Given this list of marker genes ABCA11P (ATP binding cassette subfamily A member 11, pseudogene), NR1I3, C3orf86P (NCBI Gene Id 102724231), EREG, FAM110B, TUBE1, here is a description of the gene set: Human Gene Set: HOEK_MONOCYTE_2011_2012_TIV_ADULT_3DY_DN species: Homo sapiens Genes down-regulated in monocyte 3d vs 0d in adults after exposure to 2011-2012 trivalent inactivated vaccine (A/California/7/09 (H1N1), A/Perth /16/2009 (H3N2), B/Brisbane/60/2008), time point 3D. Comment: Down-regulated DE RNA transcripts (down >= 1.5x) shared between both TIV-vaccinated donors from publication Hoek KL, Samir P, Howard LM, Niu X, Prasad N, Galassie A, Liu Q, Allos TM, Floyd KA, Guo Y, Shyr Y, Levy SE, Joyce S, Edwards KM, Link AJ (PMID 25706537) Systems biology is an approach to comprehensively study complex interactions within a biological system. Most published systems vaccinology studies have utilized whole blood or peripheral blood mononuclear cells (PBMC) to monitor the immune response after vaccination. Because human blood is comprised of multiple hematopoietic cell types, the potential for masking responses of under-represented cell populations is increased when analyzing whole blood or PBMC. To investigate the contribution of individual cell types to the immune response after vaccination, we established a rapid and efficient method to purify human T and B cells, natural killer (NK) cells, myeloid dendritic cells (mDC), monocytes, and neutrophils from fresh venous blood. Purified cells were fractionated and processed in a single day. RNA-Seq and quantitative shotgun proteomics were performed to determine expression profiles for each cell type prior to and after inactivated seasonal influenza vaccination. Our results show that transcriptomic and proteomic profiles generated from purified immune cells differ significantly from PBMC. Differential expression analysis for each immune cell type also shows unique transcriptomic and proteomic expression profiles as well as changing biological networks at early time points after vaccination. This cell type-specific information provides a more comprehensive approach to monitor vaccine responses.